The following is a description of a gene set: studied in species Homo sapiens Neutrophilic granulocytes (hereafter called granulocytes) are distinguished by multilobulated nuclei and presence of cytoplasmic granules containing antipathogenic proteins. Granulocytes comprise eosinophils, basophils, mast cells, and neutrophils, all of which are ultimately derived from hemopoietic stem cells (HSCs), a self-renewing population of stem cells located in the bone marrow. A portion of HSCs exit self-renewing proliferation and differentiate to form multipotent progenitors (MPPs). MPPs then differentiate to form common myeloid progenitors (CMPs) as well as the erythrocyte lineage. CMPs further differentiate into granulocyte-monocyte progenitors (GMPs) which can then differentiate into monocytes or any of the types of granulocytes. granulocytes are the most abundant leukocytes in peripheral blood.<br>For early granulopoiesis the CEBPA, SPI1 (PU.1), RAR, CBF, and MYB transcription factors are essential. CEBPE, SPI1, SP1, CDP, and HOXA10 transcription factors initiate terminal neutrophil differentiation.<br>Initially, RUNX1 activates SPI1 (PU.1), which is believed to be the key transcription factor driving the formation of MPPs and CMPs. SPI1, in turn, activates expression of CEBPA, an indispensable transcription factor for granulopoiesis especially important in the transition from CMP to GMP (inferred from mouse homologs in Wilson et al. 2010, Guo et al. 2012, Guo et al. 2014, Cooper et al. 2015). CEBPA, in turn, activates the expression of several transcription factors and receptors characteristic of granulocytes, including CEBPA (autoregulation), CEBPE, GFI1 (inferred from mouse homologs in Lidonnici et al. 2010), KLF5, IL6R (inferred from mouse homologs in Zhang et al. 1998), and CSF3R. Importantly, CEBPA dimers repress transcription of MYC (c-Myc). CEBPA binds CDK2 and CDK4 which inhibits their kinase activity by disrupting their association with cyclins thereby limiting proliferation and favoring differentiation of granulocyte progenitors during regular ("steady-state") granulopoiesis. The transcription factor GFI1 regulates G-CSF signaling and neutrophil development through the Ras activator RasGRP1 (de la Luz Sierra et al. 2010).<br>Inhibitors of DNA binding (ID) proteins ID1 and ID2 regulate granulopoiesis and eosinophil production such that ID1 induces neutrophil development and inhibits eosinophil differentiation, whereas ID2 induces both eosinophil and neutrophil development.<br>Major infection activates emergency granulopoiesis, the production of large numbers of granulocytes in a relatively short period of time. Emergency granulopoiesis is activated by cytokines, CSF2 (GM-CSF) and especially CSF3 (G-CSF, reviewed in Panopoulos and Watowich 2008, Liongue et al. 2009) which bind receptors, CSF2R and CSF3R, respectively, resulting in expression of CEBPB, which interferes with repression of MYC by CEBPA (inferred from mouse homologs in Zhang et al. 2010) and represses MYC less than CEBPA does, leading to proliferation of granulocyte progenitors prior to final differentiation.Both, emergency and steady-state granulopoiesis are regulated by direct interaction of CEBPA (steady-state) or CEBPB (emergency) proteins with NAD+-dependent protein deacetylases, SIRT1 and SIRT2. G-CSF induces the NAD+-generating enzyme, Nicotinamide phosphoribosyltransferase (NAMPT, or PBEF), that in turn activates sirtuins.<br>GADD45A and GADD45B proteins are essential for stress-induced granulopoiesis and granulocyte chemotaxis by activation of p38 kinase. SHP2 is required for induction of CEBPA expression and granulopoiesis in response to CSF3 (G-CSF) or other cytokines independent of SHP2-mediated ERK activation.<br>Transcription of neutrophil granule proteins (e.g. ELANE, MPO, AZU1, DEFA4), that play an essential role in bacterial killing are regulated by CEBPE and SPI1 (PU.1) transcription factors. RUNX1 and LEF1 also regulate ELANE (ELA2) mRNA expression by binding to its promoter. Reactome Pathway: Transcriptional regulation of granulopoiesis part of: Developmental Biology, and this is the list of marker genes: E2F1, H2AC7, H2AC18, H2BC12, H2BC3, STAT3, GATA2, RUNX1, H2BC14, H3-3A, CBFB, CSF3R, KLF5, IL6R, H2AJ, PML, H2BC12L, CDKN1A, CEBPB, H2BC4, H3C15, H2AX, H2BC15, H2BC11, H2AB1, RARA, CEBPA, H2AC14 (NCBI Gene Id 8331), TFDP2, H2BC13, DEK, CDK2, TAL1, CREB1, FLI1, CEBPE, H2BC21, LEF1, H2BC9 (H2B clustered histone 9), H2AC6, H2BC1, GFI1, H3C1, H2BC5, KMT2A, TFDP1, H2AZ2, H2AC4, CDK4, H2BC17, MYB, RXRA, H4C1, MYC, EP300, H2AC20, SPI1, H2BC26